The following is a description of a gene set: Pathway Definition from KEGG: E2 -> ESR1/2 -> SRC -> RAS -> RAF -> MEK -> ERK -> CREB species: Homo sapiens Human Gene Set: KEGG_MEDICUS_REFERENCE_E2_ER_RAS_ERK_SIGNALING_PATHWAY E2-ER-RAS-ERK signaling pathway. Pathway ID: N01351. Pathway type: Reference. Pathway class: nt06210 ERK signaling., and this is the list of marker genes: ATF6B, MAP2K2, ESR1, MAPK1, CREB3L1, BRAF, SRC, KRAS, NRAS, HRAS, ATF4, ESR2, ARAF, MAPK3, CREB1 (NCBI Gene Id 1385), CREB5, MAP2K1, CREB3L2, CREB3L4, CREB3, ATF2, CREB3L3, RAF1